The following is a description of a gene set: Human Gene Set: GOBP_PLACENTA_DEVELOPMENT species: Homo sapiens The process whose specific outcome is the progression of the placenta over time, from its formation to the mature structure. The placenta is an organ of metabolic interchange between fetus and mother, partly of embryonic origin and partly of maternal origin., and this is the list of marker genes: IL10, CEBPB, GATA2, NODAL, EPAS1, BIRC2, CCDC134, TTPA, PLCD3, CCN1, TMED2, WNT7B, PPARG, NDP, CCNF (NCBI Gene Id 899), PCDHA10, ADA, PRDM1, LEF1, FGFR2, KRT19, CUL7, STK3, SPINT2, SENP2, VASH2, JUNB, PLK4, HAND1, SP3, GHRL, TRIM28, RTCB, CEBPA, MME, ELF5, PARP2, STK4, PRDX3, MAP2K1, GJB5, CDX2, ITGB8, VASH1, KRT8, ASCL2, LLGL2, CYP27B1, NR2F2, SNAI1, SOD1, ASH1L, CITED1, PTGS2, MIR16-1, ADM, HES1, FBN2, CTSB, VDR, AKT1, PKD2, PCDH12, SPP1, TPPP3, NCOA1, APELA, BIRC6, RXRB, SOX15, DAZAP1, ZNF568, FOSL1, CSF2, GRHL2, NSDHL, PDGFB, MED1, STC2, LHX4, OVOL2, EGFR, LIF, SOCS3, HSD17B2, E2F7, ABCB1, TCF23, EGLN1, LHX3, ALKBH1, CDKN1B, ADGRG6 (adhesion G protein-coupled receptor G6), HIF1A, BMPR2, BMP7, IGF2, ETNK2, GCM1, EPOR, PPARD, GSE1, CDKN1C, ST14, MAPK1, WNT2, CASP8, TAF10, HTRA1 (NCBI Gene Id 5654), PLAC1 (placenta enriched 1), DEDD, BPTF, HSP90AB1, ANG, PTK2, CDX4, SPINT1, GJB3, DNAJB6, LEP, GRB2, ETV2, HEY1, RBPJ, WDR83, PARP1, GGNBP2, PLG (plasminogen), NOTCH2, FZD5, ZFP36L1, CITED2, STOX2, RBM15, BSG, TFEB, STC1, DNMT3L, PTGIS, PHLDA2 (NCBI Gene Id 7262), PKD1, ADAM19, ESRRB, DLX3, RSPO3, HEY2, MDFI, E2F8, ARNT, DCAF13, PTN, BMP5, GHSR, EOMES, LDOC1, MAP3K4, HS6ST1 (heparan sulfate 6-O-sulfotransferase 1), HSF1, MAPK14, FBXW8, TEX19